The following is a description of a gene set: part of: IGF1R signaling cascade electronically inferred by orthology from the curated human pathway Reactome Pathway: SHC-related events triggered by IGF1R This event has been computationally inferred from an event that has been demonstrated in another species.<p>The inference is based on the homology mapping from PANTHER. Briefly, reactions for which all involved PhysicalEntities (in input, output and catalyst) have a mapped orthologue/paralogue (for complexes at least 75% of components must have a mapping) are inferred to the other species. species: Mus musculus, and this is the list of marker genes: Grb2, Igf2, Shc1